The following is a description of a gene set: Genes predicted to be targets of miRBase v22 microRNA mmu_miR_697 in miRDB v6.0 with MirTarget v4 prediction scores > 80 (high confidence targets). Mouse Gene Set: MIR_697 from publication Chen Y, Wang X (PMID 31504780) species: Mus musculus, and this is the list of marker genes: Bap1 (Brca1 associated protein 1), Zfand5, Zfp462, Gcsh, Plod3, Chmp7, Ppp1cb, Mier3, Prkce, Zfp644, Lin7a, Cldn10, Hmgb2, U2surp, Gabra2, Has2, Kcna1, Nrp1 (neuropilin 1), Zbtb34, Asxl1, Sqle, Ino80d, Far2, Zfp623, Strbp, Sinhcaf, Ppa1, Kif21a, Rab5if, Klhl28, Napepld, Cdk14, Rora, Tbr1, Arhgef7, Eif5, A430033K04Rik, Rnf145, Fzd8, Cemip, Pou2f2, Car13, Fgf10, Heph, Dmrta2 (NCBI Gene Id 242620), Usp47, Zfp941, Dclre1b, Nova1, Rab23, Cd1d1, Pitx2, Slamf1, Zfp597, Hnrnph2, Ash1l, Rmnd5a, Elk3, Hnrnph1, Jmjd1c, Ubp1, Slfn5, Cntrl, Ccser2, Edil3